The following is a description of a gene set: The hierarchical steps resulting in the progressive subdivision of the anterior/posterior axis of the embryo. studied in species Mus musculus Mouse Gene Set: GOBP_BLASTODERM_SEGMENTATION, and this is the list of marker genes: Six1, Tdrd7, Shh, Tbx3, Tcf7l1 (transcription factor 7 like 1 (T cell specific, HMG box)), Fzd5, Tasor, Pld6, Wnt5a, Tdrd6, Neurog1, Nrp1, Pcsk6, Sema3f, Bmp4, Frs2, Nog, Wt1, Cripto, Lama5, Tifab (TRAF-interacting protein with forkhead-associated domain, family member B), Ednra, Tdrd1, Nckap1, Nrp2, Chrd, Sema3a, Tdrd5 (tudor domain containing 5), Tdrkh